The following is a description of a gene set: Any process that decreases the rate or frequency of muscle cell apoptotic process, a form of programmed cell death induced by external or internal signals that trigger the activity of proteolytic caspases whose actions dismantle a muscle cell and result in its death. Human Gene Set: GOBP_NEGATIVE_REGULATION_OF_MUSCLE_CELL_APOPTOTIC_PROCESS species: Homo sapiens, and this is the list of marker genes: HEY2, MIR133A1, MAPK7, KIFAP3, CFLAR, MIR19B1, GATA4, APOH, BMP7, GRIA4, MIR20A, NACA, LRP6, NOTCH1, MAP2K5, NOL3, NR4A3, HAND2, ATG5, MYOCD, SLC7A5, MIR210, MIR30E, IGF1, MIR138-1, NUPR1, STUB1, MIR17, BAG3, MIR199A1, DIPK2A, ZC3H12A, MIR145, PPP1R10, PAX8, MIR24-1, SFRP2, MDK, SIRT5, RGL2, HSPB6, AMBRA1, MIR19A, ESR1, EDN1, NFE2L2, NKX2-5, ALOX12, MIR21, MIR92A1, MIR106B, PDPK1, NRG1, SIRT4, JAK2, HSF1, DNMT1, LYPD3